The following is a description of a gene set: Binding to a glycolipid, any compound containing one or more monosaccharide residues bound by a glycosidic linkage to a hydrophobic group such as an acylglycerol, a sphingoid, a ceramide (N-acylsphingoid) or a prenyl phosphate. Mouse Gene Set: GOMF_GLYCOLIPID_BINDING studied in species Mus musculus, and this is the list of marker genes: Lama1, Thy1, Hspa2 (NCBI Gene Id 15512), Gltp, Tpp1, Gpaa1, Ceacam1, Cln3, Mag, Dpep1, Ppt1, Rtn4r, Epdr1, Lyn, Fcgr4, Ceacam2, Cln6, Manf (mesencephalic astrocyte-derived neurotrophic factor), Plekha8, Trem2, Clec4f, Vnn1, Sell, Clec4e, Clip3, Psap, Lamb1, Lamc1, Pigu, Mppe1, Cel, Hmgb1, Il2